The following is a description of a gene set: Human Gene Set: GOBP_NITRIC_OXIDE_TRANSPORT The directed movement of nitric oxide, nitrogen monoxide, into, out of or within a cell, or between cells, by means of some agent such as a transporter or pore. studied in species Homo sapiens, and this is the list of marker genes: HBA2, EDN1, HBB, AQP1, HBA1